Given this list of marker genes GJA5, PGRMC2, BAMBI (NCBI Gene Id 25805), P4HTM, PDE3A, CDH11, PLXNA4, SKIL, NFKBIZ, ANOS1, SYNPO, MCTP1, SLC6A4, PTGFRN, NPIPA8, COL5A2, EPS8 (EGFR pathway substrate 8, signaling adaptor), ERAP2, GDF7, PDLIM3, APPAT, MAP3K8, OMD, FBLN2, COPZ2, AIG1, PXDC1, PTPN14, CRISPLD1, FOXC2, SLC25A34-AS1, P3H3, NOMO3, TOX, BCAT1, HIP1R, HLA-DRB1, PTN, MYORG, PDE4A, HEXA, SERPINE2, GASK1B, LDLRAD3, FOXC1, COL1A2, GBP2, ACVR1, MIR155HG, IL18BP, LDLRAD4, CLN8, HAUS7, C1S, MX1, ERBB2, FGF18, AMPH, EPDR1, HAS2, QSOX1, TMEM231, IL11RA, GOLGA3, S1PR4, SEMA3F, IGFBP3, FBLN5, C1R (complement C1r), MIR99AHG, CPAMD8, HMCN1, CSRNP1, ITGB5, CXCL2, SOX5, C19orf33, SMAD6, CBX6, CAMK4, F2R, BMP4, NR4A2, DHH, FILIP1L, CRIM1, PLD5, RCN3, STON1, TSPAN2, SKI, APLP1, FBLN1, CLDN15, LOXL1, NOMO2, CERCAM, NOMO1, TAGLN, COL3A1, SELL, ABR, COL9A3, LINC01133, TMTC1, SYT11, CALHM5, CYBRD1, TRIM22, XAF1, IFNAR2, SELENOM, CCDC80, SELP, NPIPA1, BMX, EFEMP1, SULT1B1, CYP1B1 (NCBI Gene Id 1545), SLC16A14, TM6SF1, CCN1, RGMB, KLHL13, SMAD7, SPOCK1, NMT2, CYTL1, NUAK1, NCAM1, FADS3 (fatty acid desaturase 3), TNFRSF12A, FBN2, RND3, HTRA3, COL21A1, CDKN1A, ARHGAP4, CHST3, AIF1L, GCHFR, TNFRSF1B, PPP1R3B, PLXNA2, KANK1, GRB14, LTBP2, MECOM, NPIPA7, LMTK2, NRK, GIPC2, JAG1, PTGIS, SNX18, METRNL, PI15, HOXB3, THBS1, CRABP2, TFPI2, GALNT2, ANKRD36, CDC42EP3, PRUNE2, APOL1, MLLT1, DPYD, SSTR1, POLG2, TRH, CASP1, SLC26A7, ERAP1, MET (MET proto-oncogene, receptor tyrosine kinase), NSUN5, CUBN, PTGDS, CXCL3, KAZALD1, RPS6KA5, PLAC9, NOX4, SMTNL2, LYPD2, MGP, RUNX1T1, CRIP1, SLC8A1, CPLX1, CPE, IER3, TMEM120A, LPCAT2, COL23A1, RSPO3, FOSL2, GFOD1, ITPR2, BCL9L, SOCS2, CCN2 (NCBI Gene Id 1490), CADM1, DSE, SIDT2, USP35, IL13RA1, MCC, SULT1E1, BMP6, MYRIP, PCSK2, MPZL2, HEY2, GARNL3, IFITM1, PLK3, PTPRJ, MATN2, LTBP4, SPEG, CAPG, PKP2, GBP1, SFRP4, S100B, CLIC3, ARSJ, NCOA7, ADAMTS1, ITPR1, KCNMB1, ALCAM, GOLGA8B, DKK2, PMEPA1, FUT8, FZD8, GATA6, ABCA8, AGA, AKNA, SLC22A17, IFIH1 (interferon induced with helicase C domain 1), RTN4RL2, CDO1, ALDH1A1, GOLIM4, CNTNAP3, ABI3BP, GCA, ROM1, PCSK5, HMCN2, TMEM47, VCAM1, FAM107A, MMP16 (NCBI Gene Id 84257), LOX, HAPLN3, ZBTB16, PI16, SAMD4A, LGR4, LRIG3, ATL2, TNRC6C, SULF1, PTPRR, TP53I13, NR4A1, ARID5A, CBLN2, ASS1, CSF1, SGCE, PRSS35, NRBP2, PDGFD, MRC2, BST1, HOXA3, ABCA2, EFNA5, SH3RF2, FNIP2, RBMS3, MFAP4, TENT5A, AHNAK2, KCNN4, DIPK2A, DPP7, HNRNPA1L2, DNASE2, TLR5, TANC2, EVA1C, PTPRF, PTGER4, SEZ6L2, GUCY1B1, PELI1, PTGS1, IRF6, IFI6, DENND5B, CTSC, PTGS2 (NCBI Gene Id 5743), CDA (NCBI Gene Id 978), SH3BP4, CKB, NPLOC4, TMTC2, LYPD6, PEG10, KISS1, COL5A1, ATP2A3, SERPINE1 (serpin family E member 1), MRAP2, TRAM2, CPXM2, FGGY, DDAH1, IFI44L, ENTPD2, ZNF217, FGFRL1, EPB41L3, THBS3, NNMT, ABCA3 (ATP binding cassette subfamily A member 3), PER1, FMOD, CSF2RB (colony stimulating factor 2 receptor subunit beta), PLCG2, ID2, CXCL12, LDLR, CD58, GUCY1A1, SYT15, ID4, PLOD2, RRAS, EXT1, SEMA3G, SLIT3, GLIS2, CDIP1, ATXN1, MEDAG, CFH, GHR, here is a description of the gene set: studied in species Homo sapiens Human Gene Set: HE_LIM_SUN_FETAL_LUNG_C3_OMD_POS_ENDOTHELIAL_CELL OMD+ endo from publication He P, Lim K, Sun D, Pett JP, Jeng Q, Polanski K, Dong Z, Bolt L, Richardson L, Mamanova L, Dabrowska M, Wilbrey-Clark A, Madissoon E, Tuong ZK, Dann E, Suo C, Goh I, Yoshida M, Nikolić MZ, Janes SM, He X, Barker RA, Teichmann SA, Marioni JC, Meyer KB, Rawlins EL (PMID 36493756)